The following is a description of a gene set: from publication Baram D, Dekel O, Mekori YA, Sagi-Eisenberg R (PMID 20190146) Human Gene Set: GSE19888_CTRL_VS_TCELL_MEMBRANES_ACT_MAST_CELL_PRETREAT_A3R_INH_DN species: Homo sapiens Genes down-regulated in HMC-1 (mast leukemia) cells: untreated versus incubated with the peptide ALL1 followed by stimulation with T cell membranes. We demonstrate that the G protein Gi3 is the cellular target of the adenosine A3 receptor (A3R). By using a cell permeable peptide comprising the C-terminal end of Gαi3 fused to an importation sequence (ALL1) as a selective inhibitor of Gi3 signaling, we show that by coupling to Gi3, the A3R stimulates multiple signaling pathways in human mast cells, leading to upregulation of cytokines, chemokines and growth factors.Following contact with activated T cell membranes, endogenous adenosine binds to and activates the A3R, resulting in Gi3-mediated signaling. Specifically, the majority of ERK1/2 signaling initiated by contact with activated T cell membranes, is mediated by Gi3, giving rise to ALL1-inhibitable cellular responses. These results unveil the physiological GPCR that couples to Gi3 and establish the important role played by this G-protein in inflammatory conditions that involve adenosine-activated mast cells. We used microarrays to detail the effect of ALL1 on gene expression of HMC-1 cells activated directly by the A3 receptor, or by contact with activated T cell membranes., and this is the list of marker genes: IL4I1, AREL1 (NCBI Gene Id 9870), NPC2, USP11, UACA, SLAMF8 (SLAM family member 8), C8orf33, SHISA5, CXCL11, NFKB1, CLIC4, TAPBP, MXD1, CXCL10, APOBEC1, SLC25A44, IDO1, EVI2B, TMEM39B, GBP7, SERPINB9, TRIM34, C15orf48, SLFN13, N4BP1, TOR3A, SLC28A2, IRAK2, MRPL30, BATF2, USP18, SFMBT1, COLEC11, CNGB3, TLR2, CH25H, GZMB (granzyme B), STOML1, GNB4, IFI44L, CARM1, FBXO17, RFX1, KLHL18, SLAMF9, ANKRD1, RGS16 (regulator of G protein signaling 16), STAT5B (NCBI Gene Id 6777), MARCHF5, PIK3AP1, TOR1AIP1, ANKFY1, IL12RB1, ARHGAP8, POMP, IKZF1, RAPGEFL1, ITGB7, AXIN2, RTP4, SP110, ETV6, PARP11, SNX10, TDRD7, STXBP1, KCTD13, IFT172, SCLY, OAS1, FNBP4, SAMHD1, CNP, HLA-E, TIMELESS, UBA7, RBM43, BST2, ITGAL, ABCG1, TPX2, IFITM3, OAS2, IRF9 (NCBI Gene Id 10379), VDAC2, DTX3L, ATG16L1, IL15, GRN (granulin precursor), IFNB1, STING1, PRKX, INPP1, FPR2, FBXL14, STAT2, BCL3, MOCOS (NCBI Gene Id 55034), ZUP1, TLR3, GLA, TOR1AIP2 (torsin 1A interacting protein 2), BTG2, IRF1, SLFN12, TRIM21, FANCA, IL6, TUBB6, CCRL2, IL18BP, RSAD2, B4GALT5, APOL2, CD274, ADAR, SLFN5, TREML2, GSAP, PTPN6, IFI27L2, RARRES2, IFIT2, RGS1, DDX60, TRIM5, CMPK2, CD300LF, CCR7, PARP9, HELZ2, CD72, IRF7, ITK, GPR18, CCDC32, PIK3R5, RHOH, SGCB, SNTG2, HSH2D, APOD, LRFN2, CALHM6, CCL2, DDX4, ARHGAP30, ARF4 (ADP ribosylation factor 4), VCAM1, SETDB2, ADA, HDC, MMP13, TRIM25 (tripartite motif containing 25), TNNI3, SAMD9L, C2, GCH1, KLRK1, DCK, EFHB, PTX3, NAAA, RAC1, EIF4E3, AIDA, BLTP2, BFSP1, SH2D1A, MPEG1 (NCBI Gene Id 219972), PLAC8, NLRC5, HLA-G, SPATS2L, KANSL3, LARP1, SIRPB1, C19orf38, GZMA, CD200R1L, CASP9, CD40, HK1, BCL9 (BCL9 transcription coactivator), PTK2B, NMI, LACC1, SEMA4D, TENT4A, IFIH1, EIF2AK2, IFIT1, IL2RG (NCBI Gene Id 3561), PTPRO, PARP14, TNFAIP2, SLAMF7, OLFML3, GMPPB, SF3A2 (NCBI Gene Id 8175)